The following is a description of a gene set: Genes predicted to be targets of miRBase v22 microRNA hsa-miR-671-5p in miRDB v6.0 with MirTarget v4 prediction scores > 80 (high confidence targets). from publication Chen Y, Wang X (PMID 31504780) Human Gene Set: MIR671_5P studied in species Homo sapiens, and this is the list of marker genes: ZIM2, ZNF22-AS1, KIAA1549, RORA, RNF38 (ring finger protein 38), ZCCHC2, DCAF17, BCR, NFKB1, EXD1, FRMD6, TAPT1, RLF, RAB18, PPP4R3B, ENSG00000277067, CALN1, TBL2, LINC03104, SYPL2, CSNK1G3, C9orf78, FOXP2, SLC30A6, C11orf24, C5orf47, ANKS1B, MYRIP, CBS, CFL2, GALNT10, WDR41, RTN4, DMAC2, FTSJ1, SIAH2, SEPSECS, HMBOX1 (NCBI Gene Id 79618), LINC02909, VPS45, IQSEC3, DSTN (destrin, actin depolymerizing factor), SH3TC2, FGFR2, VPS26A, KCNMA1, THBS1, LRRN1, ACVR2A, USP46, HAPSTR1, TCAF2, SHPRH, CCDC6, TAF8, DDX39B (NCBI Gene Id 7919, DExD-box helicase 39B), PTAR1, CFTR, SYT9, HPS5, HDAC5, VSNL1, FNDC5, DIP2C, SYNPR (synaptoporin), RAG1, ST8SIA5, PASD1, AAK1, ZNF805, CD209, PTPRD, TRIM67, CAMKK2, PIK3IP1, ADCY1, EIF5B, MERTK, ACBD6, WFDC6, HAAO, GPAM, TCF12, MAP3K19, RAB12, LINC03105, SYNGR3, SSBP1, MAML2, KRT38, KCNA6, TIPARP, FAT4 (NCBI Gene Id 79633), ACTR2, ADAM11, ATP11B, SPPL3, FADS1, STYX, KRT9, CYFIP2, JADE1, SATB2, ATP8B4, HIVEP3, ADO, DVL3, SPTBN2 (spectrin beta, non-erythrocytic 2), SGK2, SPOCK1, LGALS3BP, CACNG1, ANKS1A, SNX1, KIT, MARCHF5, SPTBN1, KLF6, DENND2D, CA7, LIN9, OTUD4, GID4, UBR4, TRAPPC14, MBTD1, KDM5A (lysine demethylase 5A), EDN1, LRRC59, PTPN20, MARK1